Given this list of marker genes SOS1, EGFR, SHC1, EGF, HRAS, CDC37, HSP90AA1, NRAS, GRB2, CBL, PIK3CA, GAB1, PLCG1, PIK3R1, KRAS (NCBI Gene Id 3845), here is a description of the gene set: part of: Signaling by EGFR in Cancer Reactome Pathway: Signaling by EGFRvIII in Cancer studied in species Homo sapiens EGFRvIII (EGFR V30_R297delinsG) is the most prevalent EGFR variant in glioblastoma, but it is also found in other cancer types. In-frame deletion of the ligand binding domain in EGFRvIII is frequently accompanied with genomic amplification, resulting in over-expression of EGFRvIII. EGFRvIII dimerizes and autophosphorylates spontaneously and is therefore constitutively active